Given this list of marker genes Eif2ak3, Pdk4, Pdk2, Tcf7l2, Nfe2l2, Sp1, Tm9sf2, Tpk1, Ctnnb1, Pxylp1, Cacna1a, Comt, Pdk1, Slc7a11, Bckdk, Pdk3, Snca, Pgk1, here is a description of the gene set: Any process that modulates the frequency, rate or extent of the chemical reactions and pathways involving sulfur, the nonmetallic element sulfur or compounds that contain sulfur. Mouse Gene Set: GOBP_REGULATION_OF_SULFUR_METABOLIC_PROCESS species: Mus musculus